Given this list of marker genes IVNS1ABP, MTHFD1, TRNT1, HLA-DQB1, IKBKB, PIGG, BACH2, HYOU1, ITCH, CTBP1, LRRC8A, TNFRSF9, ZBTB24, CCND1, EPG5, GTF2E2, MS4A1, JAK3, XIAP, TNFRSF11A, SH2D1A, ATM, CBLB, NHLRC2, OAS1, CASP10, LAMTOR2, CD247, PTPRC, ERCC2, SLC25A13, TTC7A, STIM1, RNF113A, SEC61A1, ICOS, LIG1, IL21, SPINK5, ITK, MAN2B1, NFE2L2, IFIH1, CTPS1, ATP6AP2, POLD3, RNF31, SLC46A1, TARS1, TNFSF12, PTEN, IGHM, UNG, DOCK11, TLR8, CISD2, RMRP, PIK3CG, TFRC (NCBI Gene Id 7037), SP110, TIMM8A, LAT, TCN2, RAC2, NFKB2, CSNK2A1, TCF3, FAT4, ARHGEF1, ZNF341, DCLRE1C, RFXANK, ZEB2, HELLS, LRBA, KRT14, CASP8, CCNO, CXCR4, STX11, CDCA7, PRF1, STXBP2, NELFA, RTEL1, CD27, FNIP1, POLE, CCBE1 (NCBI Gene Id 147372), DNMT3B, CNBP, IL21R, PIK3R1, COG6, NFKBIA, STAT2, SHARPIN, SKIC2, PLVAP, SLC7A7, IQSEC2, POLD1, RIPK1, AK2, LCK, ADA2, ORAI1, RNF168, CD40, IKBKG, SON, CARD11, MAP3K14, FLNA, CD19, RFXAP, MPLKIP, CARMIL2, WAS, TP53, CD79A, RPA1, KMT2D, PRIM1, ALG12, MSN, MOGS, CD81, NSD2, RBM8A, IL6R, RAG1, ZAP70, CARS1, IGLL1, CTNNBL1, SLC39A7, TYMS, CD40LG, NBN, CD55, BCL10, SKIC3, MTOR, KDM6A, CORO1A, TNFRSF13C (NCBI Gene Id 115650), PRKCD, ICOSLG, MCTS1, VPS33A, SASH3, IRF2BP2, KRT5, PIK3CD, TOM1, TNFRSF13B, SIK3, AARS1, KNSTRN, SMARCAL1, RFX5, ADAMTS3, FASLG, MYSM1, SPI1, PSMB10, RAD50, FBXL4, BTK, IL6ST, MAGT1, CD79B, REL, DEAF1, ATP6AP1, PSMB9, NFKB1, IGKC, TRMU, NHEJ1, IPO8, IL2RA, SAMD9L, SH3KBP1, MALT1, PMM2, TONSL, NAE1, BLM (NCBI Gene Id 641), RNU4ATAC, GTF2H5, RAG2, CD3G, CTLA4, CD3E, CIITA, SLC5A6, IRAK4, LETM1, LYN, IL2RG, SYK, HLA-DQA1, IGHG2, ADA, CPLX1, FLII, CAVIN1, PIGT, SPPL2A, DOCK8, AICDA, SLC35C1, ERCC3, B2M, CR2, UNC13D, CD3D, EXTL3, SLC19A1, MGAT2, FAS, RASGRP1, PLCG2, IKZF1, BLNK, STAT3, RAI1, CD70, UHRF1, here is a description of the gene set: An abnormally decreased level of immunoglobulin in blood. Decreased circulating immunoglobulin concentration Human Gene Set: HP_DECREASED_CIRCULATING_IMMUNOGLOBULIN_CONCENTRATION species: Homo sapiens